Given this list of marker genes PEPD, SNRPN, WRN, UBE3A, RTEL1, ACD, WRAP53, KRT25, PARN, MOGS, TERT, CTNS, TERC, UBR1, BLOC1S3, SIM1, DTNBP1, NPM1, AP3B1, USB1, KRT71, IFT140, LAMTOR2, FGFR3, ATP10A, ABCA2, CLCN7, SLC17A5, CHN1, GNPTAB, PAH, SOX10, HPS3, OCA2, TFAP2A, RMRP, ZFX, EDNRB, TYRP1, SLC45A2, HPS6, HRAS, ZNF699, NHP2, KANSL1, TINF2, NDN, MLPH, TYR, DSTYK, MYO5A, PADI3, TGM3, PDE4D, GJB6, MAGEL2, KIT, TMCO1, LRMDA, EPG5, DPP9, SLC24A5, LIPH, SKIC2, LMNA, KITLG (NCBI Gene Id 780897), MAFB, RAB27A, WDR45, HPS5, BLOC1S5, TAFAZZIN, LRPPRC, AP3D1, LPAR6, NOP10, DHCR7, PTPN22, HPS4, SKIC3, PIGN, TP63, HPS1, ATM, PAX3, MITF, LYST, SALL4, SNAI2, KRT74, ATP7A, TYMS, CTC1, EDN3, DCT, FAS, DKC1, MC1R, here is a description of the gene set: Hypopigmentation of hair species: Homo sapiens Human Gene Set: HP_HYPOPIGMENTATION_OF_HAIR